The following is a description of a gene set: Complex febrile seizure A febrile seizure that has any of the following features: focal semiology (or associated with post-ictal neurologic abnormalities beyond drowsiness, such as a Todd's paresis), prolonged seizure beyond 15 minutes, or recurring (occurring more than once) in a 24 hour period. Human Gene Set: HP_COMPLEX_FEBRILE_SEIZURE studied in species Homo sapiens, and this is the list of marker genes: SCN9A, COG4, PRRT2, FAR1, SCN1B, SCN1A, GABRA1, CACNA1A, SLC25A12, PDE2A, ATP1A2, SCN8A, ADORA2A, PCDH19, SCN2A, GABRG2